Given this list of marker genes Slc39a8, Slc39a2, Slc39a14, Slc39a4, Slc39a1, Slc39a3, Slc39a7, Slc39a6, here is a description of the gene set: Mouse Gene Set: REACTOME_ZINC_INFLUX_INTO_CELLS_BY_THE_SLC39_GENE_FAMILY species: Mus musculus Zinc influx into cells by the SLC39 gene family